The following is a description of a gene set: species: Mus musculus The smaller of the two subunits of a ribosome. Mouse Gene Set: GOCC_SMALL_RIBOSOMAL_SUBUNIT, and this is the list of marker genes: Rps18-ps6, Rps13, Rps27a, Fau, Mrps12, Mrps15, Rps20, Rps28, Mrps9, Rps10, Rps2, Mrps18c, Rps18, Rps3a1 (NCBI Gene Id 20091), Mrps7, Eif2a, Mrps14, Mrps11, Rack1, Rps3, Mrps26, Larp4, Rps15, Rps11 (ribosomal protein S11), Mrps34, Rps4l, Rps27rt, Mrps6, Mrps28, Mrps21, Mrps27, Rps6, Dhx29, mt-Rnr1, Ddx3x, Rps17, Rps21, Rps8, Mrps10, Rps9, Rps12, Rps29, Rps4x, Mrps25, Mrps16, Eif2d, Dap3, Rps6-ps4, Rps26, Rpsa, Mrps18b, Mrpl42, Rps25, Rps23, Rps15a, Chchd1, Mrps35, Aurkaip1, Rps16, Rps27, Mrps24, Rps24, Mrps17, Mrps2, Mrps18a, Mrps22, Mrps5 (NCBI Gene Id 99095), Mrps31, Mrps33, Rps7, Npm1, D1Pas1, Mrps23, Ptcd3, Rps19, Rps27l, Rps14, Mcts1, Rps5